The following is a description of a gene set: studied in species Homo sapiens The binding of a peptide to the antigen binding groove of an MHC class II protein complex. Human Gene Set: GOBP_PEPTIDE_ANTIGEN_ASSEMBLY_WITH_MHC_CLASS_II_PROTEIN_COMPLEX, and this is the list of marker genes: HLA-DPA1, HLA-DOB, HLA-DQA1, HLA-DRB5, HLA-DQB2, HLA-DPB1, HLA-DOA, HLA-DMB, HLA-DRB4, HLA-DRA (major histocompatibility complex, class II, DR alpha, NCBI Gene Id 7930), HLA-DQA2, HLA-DMA, HLA-DRB3, B2M, HLA-DQB1, HLA-DRB1 (major histocompatibility complex, class II, DR beta 1)